The following is a description of a gene set: Genes down-regulated in brain endothelial cells from patients with Alzheimer disease. species: Homo sapiens Neurovascular dysfunction substantially contributes to Alzheimer disease. Here, we show that transcriptional profiling of human brain endothelial cells (BECs) defines a subset of genes whose expression is age-independent but is considerably altered in Alzheimer disease, including the homeobox gene MEOX2 (also known as GAX), a regulator of vascular differentiation, whose expression is low in Alzheimer disease. By using viral-mediated MEOX2 gene silencing and transfer, we show that restoring expression of the protein it encodes, GAX, in BECs from individuals with Alzheimer disease stimulates angiogenesis, transcriptionally suppresses AFX1 forkhead transcription factor-mediated apoptosis and increases the levels of a major amyloid-beta peptide (Abeta) clearance receptor, the low-density lipoprotein receptor-related protein 1 (LRP), at the blood-brain barrier. In mice, deletion of Meox2 (also known as Gax) results in reductions in brain capillary density and resting cerebral blood flow, loss of the angiogenic response to hypoxia in the brain and an impaired Abeta efflux from brain caused by reduced LRP levels. The link of MEOX2 to neurovascular dysfunction in Alzheimer disease provides new mechanistic and therapeutic insights into this illness. Human Gene Set: WU_ALZHEIMER_DISEASE_DN from publication Wu Z, Guo H, Chow N, Sallstrom J, Bell RD, Deane R, Brooks AI, Kanagala S, Rubio A, Sagare A, Liu D, Li F, Armstrong D, Gasiewicz T, Zidovetzki R, Song X, Hofman F, Zlokovic BV (PMID 16116430), and this is the list of marker genes: MAF, REM1, FADS2, IFITM1, PDE1A, NUPR1, ANK3, HSPA2, RPL37A, NR4A2, PDE1B, CDK10, CD2BP2, ADIRF, ELN, ADAMTS2, PLEC, DEFB4A, EIF2S3